Given this list of marker genes Col18a1, Map4, Gata2, Ly6a, Edn1, Snai1 (NCBI Gene Id 98875), Acta2, Fn1, Ctsl, Plk4, Itgb1, Col5a2 (collagen, type V, alpha 2), Dck, Ccl2, Mcm3, Pla2g4a, Il4ra, Col4a2, Mpdz, Rbbp6, Brca1, Top1, Tgfb3, Igfbp7, Gadd45b, Rpsa, Ncam1, Inhba, Oat, Pafah1b1, Irgm1, Tead2, Cdh2, Inhbb, Odc1, Smarcd1, Zfx, Ccn2, Tpp2, Smad1 (SMAD family member 1), Pkp1, Col3a1, Ccl7, Nr2f1, Ctla2a, Col1a1, Cyp1b1, Fbln2, Ppic, Jun, Pdgfa, Pros1, Tnc, Mki67 (antigen identified by monoclonal antibody Ki 67), Hmgb1, Abcb1b, Kifc5b, Col4a1, Furin, Cct6a, Csf1, Timp1, Rbl1, Chrnb1 (NCBI Gene Id 11443), Glg1, Cenpa, Clu, Timp3, Rhox5, Serpine1, Chek1, Traf3 (TNF receptor-associated factor 3), here is a description of the gene set: Genes up-regulated in MMH-RT cells (hepatocytes displaying an invasive, metastatic phenotype) during epithelial to mesenchymal transition (EMT). Polarized hepatocytes expressing hyperactive Ha-Ras adopt an invasive and metastatic phenotype in cooperation with transforming growth factor (TGF)-beta. This dramatic increase in malignancy is displayed by an epithelial to mesenchymal transition (EMT), which mimics the TGF-beta-mediated progression of human hepatocellular carcinomas. In culture, hepatocellular EMT occurs highly synchronously, facilitating the analysis of molecular events underlying the various stages of this process. Here, we show that in response to TGF-beta, phosphorylated Smads rapidly translocated into the nucleus and activated transcription of target genes such as E-cadherin repressors of the Snail superfamily, causing loss of cell adhesion. Within the TGF-beta superfamily of cytokines, TGF-beta1, -beta2 and -beta3 were specific for the induction of hepatocellular EMT. Expression profiling of EMT kinetics revealed 78 up- and 235 downregulated genes, which preferentially modulate metabolic activities, extracellular matrix composition, transcriptional activities and cell survival. Independent of the genetic background, platelet-derived growth factor (PDGF)-A ligand and both PDGF receptor subunits were highly elevated, together with autocrine secretion of bioactive PDGF. Interference with PDGF signalling by employing hepatocytes expressing the dominant-negative PDGF-alpha receptor revealed decreased TGF-beta-induced migration in vitro and efficient suppression of tumour growth in vivo. In conclusion, these results provide evidence for a crucial role of PDGF in TGF-beta-mediated tumour progression of hepatocytes and suggest PDGF as a target for therapeutic intervention in liver cancer. Mouse Gene Set: GOTZMANN_EPITHELIAL_TO_MESENCHYMAL_TRANSITION_UP studied in species Mus musculus from publication Gotzmann J, Fischer AN, Zojer M, Mikula M, Proell V, Huber H, Jechlinger M, Waerner T, Weith A, Beug H, Mikulits W (PMID 16607286)